Given this list of marker genes Syt8, Apob (apolipoprotein B), Wnt5a, Necap2, Cltb, Pacsin3, Syt11, Cops8, Itsn2, Grk3, Grb2, Pacsin2, Trf, Cd3g, Rab5a, Scarb2, Syt2, Egf, Gak, Avpr2, Fzd4, Areg, Itsn1, Nedd8, Cops7b, Ldlrap1, Hspa8, Adrb2, Pik3c2a, Agfg1, Vamp8, Ston1, Syt9, Necap1, Cops7a, Rab5c, Slc2a8, Hip1 (huntingtin interacting protein 1), Ldlr, Cd4, Tor1a, Fnbp1l, M6pr, Gps1, Sh3gl3, Sh3kbp1, Fcho2, Ubqln2, Arpc5, Arrb2, Cops4, Synj2, Syt1, Cops6, Ston2, Cops5, Grk2, Rps27a, Slc18a3, Cops2, Bin1, Dnajc6, Gapvd1, Aak1, Sh3gl2, Reps2, Igf2r, Avp, Arpc1a, Actb, Uba52 (ubiquitin A-52 residue ribosomal protein fusion product 1), Tor1b, Cftr, Rab5b (NCBI Gene Id 320645), Amph, Ap2a1, Synj1, Snx18, Pacsin1, Uba52rt, Tgoln1, Vamp3, Fnbp1, Epn2, Sh3gl1, Pip5k1c, Epn1, Cops3, Tacr1, Egfr, Snap91, Reps1, Cbl, D130043K22Rik, Arpc2, Actg1, Vamp4, Ubqln1, Chrm2, Arf6, Dvl2, Btc, Hbegf, Ap2s1, Vamp2, Arfgap1, Ocrl, Agtr1a, Fcho1, Ereg, Stam, Actr2, Ubb, Dnm2, Actr3, Lrp2, Ap2b1, Tfrc, Eps15l1, Ubc, Dab2, Tgfa, Arpc3, Eps15, Ap2a2, Hgs, Dnm1 (NCBI Gene Id 99078), Ap2m1, Clta, Arrb1, Stam2, Il7r, Arpc4, Snx9, Cd3d, Picalm, Trip10, Dnm3, Cltc, Epgn, Hip1r (huntingtin interacting protein 1 related), here is a description of the gene set: Clathrin-mediated endocytosis studied in species Mus musculus Mouse Gene Set: REACTOME_CLATHRIN_MEDIATED_ENDOCYTOSIS